The following is a description of a gene set: Neighborhood of CBFB core-binding factor, beta subunit in the GNF2 expression compendium Human Gene Set: GNF2_CBFB species: Homo sapiens Neighborhood of CBFB, and this is the list of marker genes: KHDRBS1, FNBP1, RCHY1, EIF3D, IFI16, PSMB8, HNRNPF, ZBTB1, RNF4, CNOT7, CSK, ZC3H15, RBMX, NONO, SRRM1, FAM111A, MFNG, INPP5D, AIMP1, HDAC1, CBFB, PSMA1, RBM15, LCP1, POLR2G, DOCK2, TAOK3, MAPRE1, HNRNPDL, PSMB10